Given this list of marker genes Syt11, Mmrn2, Emilin1, Mapkbp1, Nod2, Klk5, Rab34, Pten, Lgals9, F2rl1, Grn, Pgc, Emilin2, Klk7, Havcr2, Nlrp10, Arg2, Foxp1 (NCBI Gene Id 73231), Cyba, Unc13b, here is a description of the gene set: Any process that modulates the frequency, rate or extent of defense response to bacterium. Mouse Gene Set: GOBP_REGULATION_OF_DEFENSE_RESPONSE_TO_BACTERIUM species: Mus musculus